Given this list of marker genes Ccne2, Ppp2r1b, E2f1, Cdkn1a, Rbl2, Ccnh, Cul1, Ppp2r2a, E2f3, Cdkn1b, Cdkn1c, Tfdp1, Rb1, Cdk4, Ubb, Rps27a, Cdkn2b, Ccnd1, Ccne1, here is a description of the gene set: electronically inferred by orthology from the curated human pathway studied in species Mus musculus Reactome Pathway: G1 Phase This event has been computationally inferred from an event that has been demonstrated in another species.<p>The inference is based on the homology mapping from PANTHER. Briefly, reactions for which all involved PhysicalEntities (in input, output and catalyst) have a mapped orthologue/paralogue (for complexes at least 75% of components must have a mapping) are inferred to the other species. part of: Mitotic G1 phase and G1/S transition